Given this list of marker genes ZNF14, APBB1IP, RNF166, CNGA1, MFAP2, PPIL2, ABHD15, PDPK1, ITPR1, PRRT1, CCDC157, OS9, DNMT3B, TOR1A, SATB1, MFGE8, GDF3, MYO1F, CYLC2, CCL4, CACNG3, FRAT2, H6PD, ST3GAL6, PLCG1, PPCS, IDNK, ABCB1, SUPT4H1, ITGB5, UBE2H, KCNV2, ORMDL3, EML3, SV2B, KIF21B, ELOVL7, NISCH (NCBI Gene Id 11188), LPXN, LHFPL4, RHO, SEMA4F, HERC3, VPS37B, PDCD4, RPS5, DIO2, DMWD, BCL2L11, HID1, TLE4, CXCR2, TOGARAM1, TMEM91, HAO2, SMAP2, PTPN22, DSE, SYNPO2L, CTSW, HEXIM2, APPL2, BORCS6, MOSMO (modulator of smoothened), GPR18, TTC3, IRAG2, IL1RN, AASDH, HLA-DOA, ZFP30, CABP7, GAB1, WDR45, CAMK1D, ID2, BFAR, FRYL, SMIM3, ATXN1 (NCBI Gene Id 7912), EPB41L3, F2RL1, SNRK, B4GALNT1, SLC9B1, BAIAP3, SLC24A3, DAPK2, UNC119B, P2RY13, CAMK4, MALT1, C5orf46, GTPBP2, GTF2IRD2, CDKN1B, VWA3A, SYTL3, SH2D1A (NCBI Gene Id 4068), TUSC2, CLCF1, H2BC18 (NCBI Gene Id 729127), FNBP4, DNAJC5G, C3AR1, RACK1, FOXJ2, PYGM, NACC2, IRAK4, ACAD10, ACP3, EIF3F, EPSTI1, MCTP2, FBXL5, LUC7L2 (LUC7 like 2, pre-mRNA splicing factor), PLAUR, CENATAC (NCBI Gene Id 338657), MXRA8, SARAF, ACSS1, GAS7, SLC52A3, UBALD1, PHF23, ARHGAP26, CNRIP1, RALGAPA2, NOTCH1, PDE4B, PREX1, TRAFD1, CCDC6, AGPAT4, SIRT3, IKZF1, EVL, NEDD4, FILIP1, SDF2, FCGRT, SMYD1, IGF2, BCORL1, TMEM63A, NSMAF, GRAMD2B, BPNT2, SLC12A7, ADGRE5, GP6, SEL1L2, PXN, RSPH4A, GPR160, PPP1R13L, ZNF839, ZAP70, TTC13, TCF7, STXBP2, STX16, GABBR1, GIMAP8, ZCCHC18, SESN2, CMAS, USP32, SPTBN2, EML5, PAK3, PDE7A, GZMK, CXCR6, FAM174B, CALHM6 (calcium homeostasis modulator family member 6), DUSP22, MBLAC2, CTSA, CCR2, TMEM231, HGSNAT, KLRK1, DSG2, MPPE1, ALPL, LYST, ARL6IP5, NKAIN4, NCALD, PBXIP1, CCDC138, RAPGEF4, COX7A2L, ATP2B4 (ATPase plasma membrane Ca2+ transporting 4), DTX1, B4GALT5, PDE2A, SCGN, here is a description of the gene set: from publication Hill JA, Feuerer M, Tash K, Haxhinasto S, Perez J, Melamed R, Mathis D, Benoist C (PMID 18024188) The transcription factor Foxp3 is usually considered the master regulator for the CD4+CD25+ Genes up-regulated in comparsion of ActCD8 versus ActTreg (see Fig. 1 in the paper for details). species: Homo sapiens Human Gene Set: GSE7460_CD8_TCELL_VS_TREG_ACT_UP